The following is a description of a gene set: Human Gene Set: GOBP_INTERSTRAND_CROSS_LINK_REPAIR Removal of a DNA interstrand crosslink (a covalent attachment of DNA bases on opposite strands of the DNA) and restoration of the DNA. DNA interstrand crosslinks occur when both strands of duplex DNA are covalently tethered together (e.g. by an exogenous or endogenous agent), thus preventing the strand unwinding necessary for essential DNA functions such as transcription and replication. studied in species Homo sapiens, and this is the list of marker genes: CENPS, SPRTN, HROB, FANCD2, MCM9, POLN, FANCA, FANCM, FAAP20 (FA core complex associated protein 20), HMCES, NUCKS1, ERCC6L2, CENPX, XPA, RAD51, EXO5, FANCI, VCP, FAN1, RFWD3, DCLRE1C, ATR, FAAP100, ERCC1, FANCB, MCM8, RAD51D, RNF168, RNF8, FIRRM (NCBI Gene Id 55732), FANCG, DCLRE1A, FANCE, FANCF, RAD51AP1, FANCC, FAAP24, NEIL3, ERCC4, DCLRE1B, FANCL, XRCC3